The following is a description of a gene set: Genes up-regulated in comparison of neutrophils versus dendritic cells (DC). from publication Abbas AR, Baldwin D, Ma Y, Ouyang W, Gurney A, Martin F, Fong S, van Lookeren Campagne M, Godowski P, Williams PM, Chan AC, Clark HF (PMID 15789058) Human Gene Set: GSE22886_NEUTROPHIL_VS_DC_UP studied in species Homo sapiens Immune cell-specific expression is one indication of the importance of a gene's role in the immune response. In order to identify such patterns, we set out to broadly profile gene expression in a variety of immune cells., and this is the list of marker genes: C5AR2, SLC5A1, MINDY1, PIM2, DDX4, ALX1 (ALX homeobox 1), LHX6, FLT4, BRCA1, SCD5, MEFV, SELL, ALPK3, ERN2, KIT, KCNJ15, FOXA1, FCGR3B, FLOT1, RIPOR2, CEACAM1, LINC00623, NUP214, SIGLEC8, DEFA6, FAM86C1P (NCBI Gene Id 90960), CSF3R, KRT19P2, RAD54L, LAMP5, CD300A, RAB11FIP5 (RAB11 family interacting protein 5), LALBA, TNFSF10, HOPX, CLDN18, OASL, SLIT2 (slit guidance ligand 2), RNF122, ADGRE3, GGTLC2, POU2AF1, H1-2, TTC39A, CEBPD, RUBCNL, BTC, PCP4, PDK3, PRKCZ-AS1, HERC5, GCA, RSAD2, FUT9, IL9R, CXCL1, SMIM27, GPLD1, ITIH3, OGDHL, APLNR, TAS2R1, SIGLEC5, TPPP, SCNN1G, DUSP1, MATN1, PVRIG, PDE4B, PPP1R17, PCDHGC3, CAMP, GRIK1, ALDH1L1, ISG20, WAS, FBXO40, MAGEB3, CEP170B, PAQR6, RNF141, INSL6, TINAGL1, ADAM18 (ADAM metallopeptidase domain 18), KLRD1, RORB, NR5A2, ZEB1, ARSF, RADX, CHST4, AFF2, BASP1, CUZD1, PROZ, CELSR1 (NCBI Gene Id 9620), B3GAT1, TMEM35A, CRYM, KLF2, UTY, LGI2, ADGRG3, CXCR1, IFITM1, CFTR, ODAM, KRT32, KCNA5, L3MBTL1, FOXJ1, ITIH5, MPP3, NHERF4, ZNF460, RAB36 (NCBI Gene Id 9609), MTAP, ZNF552, FSTL4, NR6A1, DGKG, LIMK2, SYNM, SIRT3, BCORL1, TRAC, FGL1, NECAB2, RGS4, POLB, FPR1, BCO1, PTGS2, NOL4 (NCBI Gene Id 8715), ELAPOR1, SLC26A10P, OR2W1, ETV1 (ETS variant transcription factor 1), MAGEL2, BIRC5, RAB6B, H4C8, SCYL3, SOX3, STMN2, XKR8, NRF1, TREM1, CEP41, DKK3, VNN3P, SLITRK2, PHF7, TSC22D3, SLC18A1, GPSM2, CNR2, CIT, NCR2, NCR3 (NCBI Gene Id 91958), MCTP2, SLC24A3, KRT35, VNN2, HEY1 (NCBI Gene Id 23462), ST20, IFITM2, TUFT1, PPCDC, S100P, GLB1L2, FCN1, STK17B, BAMBI, LTB, DPEP3, SLC34A1, ADAM8, PTGDR2, APOBEC3A, ESR2, RLBP1, SIK1, SNAP91, SCG2, S100A12, PRF1, MPPE1, PHC2, EFHC2, ING1, LRRC1, CLEC4E, EPHB1, TREML2, BTN3A1, RIMS2, TNFRSF10C, SLC39A2